Given this list of marker genes CCL26, NES, DEFB133, DEFB1, CNIH4, CCL16, DEFB130A, DEFB106A, DEFB4A, CCL22, CCL7, MSMP, DEFB103B, CCRL2, CCL18, CCL14, CCL21, CCL11, STAT3, NARS1, CXCL13, CCL24, CCL4 (NCBI Gene Id 6351), CCL15, CCL3, DEFB103A, JAK1, XCL1, STAT1, DEFB106B, CCL2, CX3CL1, CREB3, CCL19, DEFB114, DEFB110, DEFB130B, CCL3L3, CCR2, CCL23, CCL8, CCL25, DEFB109B, XCL2, CCL20, CCL4L2, CCL13, CCL5, CCL1, CCL27, here is a description of the gene set: species: Homo sapiens Human Gene Set: GOMF_CCR_CHEMOKINE_RECEPTOR_BINDING Binding to a CCR chemokine receptor.